Given this list of marker genes RPL9, RPL36, RPS18, RPL15, RPS27A, RPL36A, ETF1, 18S rRNA, RPS17, RPL26L1, GSPT1, 5S rRNA, RPS15, RPL35, RPL10L, RPLP0, RPL22L1, RPL19, RPS23, RPL17, 5.8S rRNA, NCBP1, RPS19, RPL12, RPL37, RPS27, RPS15A, RPL13A, RPS21, RPS12, 28S rRNA, RPL30, RPS10, RPL10A, RPL41, RPL35A, RPS4Y1, RPL37A, RPL13, RPL10, RPS16, RPS13, RPL7A, RPL5, RPSA, RPLP2, RPS4X, RPL39L, RPS8, RPS25, RPS7, RPS11, RPL39, RPL23, RPL21 (ribosomal protein L21), RPL36AL, RPL32 (NCBI Gene Id 6161), RPS29, RPS26, RPS24, RPL4, RPL26, RPL11, RPL24, RPS28, RPS27L, RPS5, RPL28, RPL29, RPS6, UBA52, RPL38 (ribosomal protein L38), RPL18A, RPS4Y2, RPL23A, UPF1, NCBP2, RPL3, RPL6, RPL34, RPLP1, RPS2, RPS3A, RPL8 (ribosomal protein L8), RPL3L, RPL22, RPS20, RPL31, RPL7, RPS3, RPL18, RPL27A, PABPC1, FAU, RPS9, RPL14, EIF4G1, RPL27, GSPT2, RPS14, here is a description of the gene set: Reactome Pathway: Nonsense Mediated Decay (NMD) independent of the Exon Junction Complex (EJC) Nonsense-mediated decay has been observed with mRNAs that do not have an exon junction complex (EJC) downstream of the termination codon. In these cases the trigger is unknown but a correlation with the length of the 3' UTR has sometimes been seen. The current model posits a competition between PABP and UPF1 for access to eRF3 at the terminating ribosome. Abnormally long 3' UTRs may prevent PABP from efficiently interacting with eRF3 and allow UPF1 to bind eRF3 instead. Long UTRs with hairpin loops may bring PABP closer to eRF3 and help evade NMD.<br>The pathway of degradation taken during EJC-independent NMD has not been elucidated. It is thought that phosphorylation of UPF1 by SMG1 and recruitment of SMG6 or SMG5 and SMG7 are involved, as with EJC-enhanced NMD, but this has not yet been shown. part of: Nonsense-Mediated Decay (NMD) studied in species Homo sapiens